Given this list of marker genes HJV, MIR100, MIR302C, SMAD7, ADAM17, CITED2, EGR1, FERMT1, ADAM9, ECSIT, TGFB1I1, DMRT1, MIR26A1, BMP4, DACT1, CDH5, MIR18A, SKOR2, GCNT2, TGIF1, GDF10, EMILIN1, MIR9-1, MIRLET7A1, BMPR2, FSHB, ARID4A (NCBI Gene Id 5926), DAB2, SIRT1, AXIN1, IL17F, MIR483, RUNX2, MIR30A, LATS1, MIR323A, CTDSPL2, TET1, MIR204, MIR199A1 (microRNA 199a-1), MEN1, ITGB5, NODAL, SPRY1, SPRED3, CHRD, GATA4, ZFYVE9 (zinc finger FYVE-type containing 9), ITGB8, LTBP3, SMPD3, BRMS1, SMAD1, DLX3 (distal-less homeobox 3), FSTL4, GDF15, PCSK6, DUSP22, TOB1, SMAD3, SMAD5, MIR195, TMEM53, FBXL15, BMP2, MIR20A, TNFAIP6, LATS2, FKBP8, HES5, WNT1 (Wnt family member 1), OVOL2, MIR106A, GDF6, XBP1, ZMIZ2, TMEM119, SOST, ID1, MIR490, CDKN1C, FBN2 (NCBI Gene Id 877), ZNF703, PPM1L, FERMT2, RNF111, HTRA3, CRIPTO3 (NCBI Gene Id 6998), SUDS3, GDF2, ATOH8, NOTCH1, RGMB, CREBBP, LDLRAD4, LEFTY1, MIR17, GREM1, ZEB1, STUB1, CRB2, ITGA8, HTRA1, PPM1A, BAMBI, ZMIZ1, DAND5, NEO1, PTK2, SMAD4, ZNF8, NPNT, GDF9, HSPA1A, PIN1, NOTCH2, MSTN, SKOR1, CER1, HDAC2 (NCBI Gene Id 3066), SMURF1, HPGD, ETV2, ONECUT2, VWC2L, SKI, PRDM16, INTS9, MIRLET7G, VEPH1, LTBP1, SFRP1, RBPJ, TSC22D1, EID2, SHH, LRP2, ADISSP, MIRLET7F1 (microRNA let-7f-1), AKAP3, MIR181A2, BMP10, SH2B1, ASPN, EP300, MIR27A, NOMO1 (NODAL modulator 1), APPL2, GPR155, SMAD6, FKBP1C, TMPRSS6, PDPK1 (NCBI Gene Id 5170), SLC2A10, CHRDL2, COMP, TGFBR2, UBE2D1, HSPA5, RBPMS2, FURIN, XIAP, TAB1, POU5F1, SAP30, FLCN, AMHR2, CDKN2B, MIR140, VASN, SAP130, SCUBE3, SELENON (selenoprotein N), GLCE, BMPR1A, ERO1A, STRAP, FSTL5, SPTBN1 (NCBI Gene Id 91654), NKX2-1, MIRLET7B, LPXN, NUP93, JAK2, SNW1, LRP1, ERFE, GDF7, SNX25, NLK, MYOCD, MIR199B, TTK, ITGB1, TGFBR1, CRIM1, BMP5, GDF11, COL1A2, CITED1, ZC3H3 (zinc finger CCCH-type containing 3), FST, SULF1, FOXH1, CREB1, MIR101-1, PEG10, MIR130A, SOX11, APPL1, TWSG1 (twisted gastrulation BMP signaling modulator 1), ONECUT1, MIR23A, ZNF451, MIR212, ACVR2A, WWTR1, NOG, FMOD, MIR497, BECN1, AMH, CAV2, SFRP4, CFC1B, MEGF8 (multiple EGF like domains 8, NCBI Gene Id 90198), SORL1, MSX2, FGF9, CCN1, MIR93, ACVR1, UCMA, MAPK14, SPI1, MIR183, GPC3, USP9Y, MIR15B, MIR26B, COL3A1 (NCBI Gene Id 1281), TSKU, LOX, PARP1, SIN3A, GDF3, GLG1, INHBA (inhibin subunit beta A), SDCBP, MIR214, SINHCAF (SIN3-HDAC complex associated factor), MIR372, CCN3, CDH3, NRROS, MAPK3, MECOM, FSTL3, MIR27B, GREM2, GIPC1, PTPRK, SFRP2, TP53, CD109, RASL11B, BMP6, SMAD9, PIAS2, TMEM100, ACVR2B, MIR30B, BMP7, ILK, HFE, PBLD, FOLR1, BRMS1L, UBE2O, LEF1, JUN, MIR145 (NCBI Gene Id 406937), ATF2, PELO, CAV1, KIAA0319 (NCBI Gene Id 9856), FOS, MIR424 (microRNA 424), MIR498, SCX, APOA1, MIR342, SMAD2, MICOS10-NBL1, ACVR1B, HIVEP1, PALM2AKAP2, MIR373, PPARG (peroxisome proliferator activated receptor gamma), VWC2, NGLY1, MIR361 (microRNA 361), AKAP4, MIR21, MIR885, FAM89B, TGFBR3L, DLX1, ING1 (NCBI Gene Id 3621), RBBP7, UBE2D3, TGFB1, DDX5, SKIL, MAP1LC3A, ZNF423, TGFBRAP1, DACT2 (dishevelled binding antagonist of beta catenin 2), STAT3, FUT8, SMURF2, HIPK2, MIR19A, ADAMTSL2, NDP, LRRC32, WNT5A, WFIKKN1, FSTL1, MIR302B, ING2, NBL1, PDCD4, SOSTDC1, EXT1, MTMR4, TGFBR3, ZBTB7A, IGSF1, CIDEA, PRMT1, NREP, DKK3, PALS1, PML, CRIPTO (NCBI Gene Id 6997), MIR29B1, KCP, FGF10 (NCBI Gene Id 2255), LEMD3, USP15 (ubiquitin specific peptidase 15), GDF5, USP9X, CFC1, PPARA, CLDN5, SNX6, RBBP4, SPRED2, THBS1, MIR376C, INHBB, ACVRL1, WFIKKN2, RGMA, FAM83G, DLX5, GOT1, ELAPOR2, ZEB2, FOXD1, CHRDL1, MIR564 (microRNA 564), MAP3K7, DKK1, IL17RD, BMPR1B (NCBI Gene Id 658), BCL9, MAGI2, MIR19B1 (NCBI Gene Id 406980), HDAC1, BCL9L, ZYX, FNTA, NOMO3, OGT, ARID4B, TGFB2, ITGB6, ARK2C, SRC, MIR98, LTBP4, SPRED1, LTBP2, SPART, CSNK2B, PMEPA1, BMPER, STK11, DSG4, HOXA13 (homeobox A13), RBPMS, TBX20, NUMA1, PXN, TFAP2B, FZD1, NCLN, RGCC, ARRB2 (NCBI Gene Id 409), NFIA, HSP90AB1 (heat shock protein 90 alpha family class B member 1), CRKL, TGIF2, ACVR1C, ABL1, TGFB3, SMAD5-AS1, TRIM33, HES1, SPRY2, MIR146A (NCBI Gene Id 406938), SAP30L, MIR142, MIR205, MSX1, MIR520C, LRG1, PSG9, CILP, SLC39A5, CHST11, ITGA3, KDR, HTRA4, MIR125B1, FKBP1A, MIR210, CAV3, FBN1, ENG, here is a description of the gene set: Human Gene Set: GOBP_CELL_SURFACE_RECEPTOR_PROTEIN_SERINE_THREONINE_KINASE_SIGNALING_PATHWAY The series of molecular signals initiated by an extracellular ligand binding to a receptor on the surface of the target cell where the receptor possesses serine/threonine kinase activity, and ending with the regulation of a downstream cellular process, e.g. transcription. species: Homo sapiens